Given this list of marker genes SLC1A2, ALOX15B, CCL5, PSMB8, H2AC13, MCM5, TUBA1C, TTYH2, IDO1, SAT1, CSF2RA, PLD2, LONRF1, PXYLP1, DENND5A, SOD2, EDEM1, EBI3, GRAMD1A, TESPA1, LAMB3, AK4, PARP10, H2BC5, PGK2, NECTIN2, DNAJC18, MMP7, TRAF1, TNIP2, GCH1, ELOVL7, PRRG2, DHCR7, SLC44A1, EPSTI1, IRF1, FSCN1, H2BC12, COL7A1, CYP27B1, PTPN2 (NCBI Gene Id 5771), PLAT, CCDC115, SLC2A6, LRRC61 (leucine rich repeat containing 61), SDC4, PTPN1, LXN, JAK3, SCN1B, CYTIP, SRGN (NCBI Gene Id 5552), MRPL49 (mitochondrial ribosomal protein L49), F11R, IL21R, PHLDB3, POLI, LAD1, BCL2L11, IL7R, CD40, TNFRSF4, ISG20, PNRC1, RHOF, IL15RA, C17orf49, H2AC14, TNFAIP2, HMGN2P46, KYNU (kynureninase), H2AC6, LMNB1, OPTN, C1S, NR2E3, H2BC12L, SHD, EDC4, SLC7A11, TMPRSS13, GPR132, CMTR1, CD200, TNFAIP1, FADS1, CSRNP1, SELENOM, GADD45B, GADD45A, TNFRSF18, ABTB2, ARHGAP25 (NCBI Gene Id 9938), INHBA (inhibin subunit beta A), BASP1, SPACA7, RASGRP1, NFKB1, TRIP10, BMAL2 (basic helix-loop-helix ARNT like 2), MSMO1, CFLAR, NFKBID, ARFRP1, APOL1, RAB29, FBXL8, DUSP5, PARP9, HAPLN3 (NCBI Gene Id 26283), IDI1, SLC9B2, MCL1, FBXL4, SNHG15, TBRG4 (NCBI Gene Id 9238), FADS2, LDLR, H4C8, APOL3, HOPX, NFKBIA, CTRL (NCBI Gene Id 1506), ENO1, C15orf48, TAP1, LILRA3, MYL5, IL2RA, PIM2 (NCBI Gene Id 11040), TXN, CCR7, NME3, TNFAIP3, LINC03025, VEGFA, TSFM, HEXIM1, RUFY3, TNFRSF9, ETV7, FXYD6, C1R, RNF31, HMGCR, DUSP4, H2BC7, PDE4B, C4orf3, RYBP, NFKBIZ, RELB (RELB proto-oncogene, NF-kB subunit), TRADD, FTH1, TNFAIP6, SCD, MCOLN2, HSD17B7, TAMALIN, EHD1, N4BP2L1, CDKN1A, C1QTNF1, C17orf58, TRAF2, SPG7, VWA1, DSE, MYO1G, CD274, SOCS3, STAT4, SC5D, PIM3, ZNFX1, MPZL1, NABP1, PEF1 (penta-EF-hand domain containing 1), MAP1LC3A, GP1BA, GBP1, FDPS, CXCR4, RFTN1, H2BC6, CARINH, SRI, NCK2, ACHE, ARID5B, CYRIA, C5orf15, H2BC10, SLC39A1, GBP4, CRLF2, here is a description of the gene set: The recent discovery of the human B1 cells, identified by the expression of CD20, CD27 and CD43 in absence of expression of CD70 and CD69 has been subject of debate. Some studies have raised the possibility that these cells are B cells differentiating towards the plasmablast and plasma cell stage rather than being the human counterpart of murine B1 cells. No further in depth studies have been performed. Therefore, a functional comparison was made between, the proposed B1 cells and plasmablasts. We observed that for several functional characteristics (distribution of isotypes of spontaneously producted antibodies, production of antigen-specific antibodies after vaccination with both T-cell dependent as well as T-cell independent antigen, the proposed B1 cells behaved similar to plasmablasts. In addition, we were able to differentiate the proposed B1 cells in vitro, indicating that they are not from a distinct lineage as the murine B1 cells. Gene expression analysis revealed that these cells cluster between memory B cells and plasmablasts, contradicting them being the genuine human counterpart of murine B1 cells, rather revealing a preplasmablast phenotype. from publication Covens K, Verbinnen B, Geukens N, Meyts I, Schuit F, Van Lommel L, Jacquemin M, Bossuyt X (PMID 23613519) Human Gene Set: GSE42724_MEMORY_VS_B1_BCELL_DN Genes down-regulated in B lymphocytes: memory versus B1. studied in species Homo sapiens